The following is a description of a gene set: Any process that stops, prevents, or reduces the frequency, rate, or extent of cell adhesion mediated by integrin. studied in species Mus musculus Mouse Gene Set: GOBP_NEGATIVE_REGULATION_OF_CELL_ADHESION_MEDIATED_BY_INTEGRIN, and this is the list of marker genes: Snai2, Acer2, Nexmif, Ptpn11, Hrg, Cyp1b1, Wnk1, Jam3, Muc1, Serpine1, Swap70